The following is a description of a gene set: species: Homo sapiens Human Gene Set: GOMF_TRANSMEMBRANE_RECEPTOR_PROTEIN_PHOSPHATASE_ACTIVITY Combining with a signal and transmitting the signal from one side of the membrane to the other to initiate a change in cell activity by catalysis of the reaction: a phosphoprotein + H2O = a protein + phosphate., and this is the list of marker genes: PTPRB, PTPRG (protein tyrosine phosphatase receptor type G), PTPRA, PTPRT, PTPRZ1, PTPN6, PTPRD, PTPRE, PTPRH, PTPRN2, PTPRU, PTPRC, PTPRM (protein tyrosine phosphatase receptor type M), PTPRK, PTPRO, PTPRF, PTPRR